The following is a description of a gene set: studied in species Mus musculus Mouse Gene Set: GOBP_RESPONSE_TO_INTERLEUKIN_17 Any process that results in a change in state or activity of a cell or an organism (in terms of movement, secretion, enzyme production, gene expression, etc.) as a result of an interleukin-17 stimulus., and this is the list of marker genes: Notch1, Il17ra, Il17f, Cntnap2 (contactin associated protein-like 2), Ccl1, Socs3, Traf5, Traf2, Traf6, Srsf1, Mir1896, Traf3ip2, Cxcl1, Il17a, Usp25, Trim32, Dcp1b, Il1b, Il6, Fmr1, Shank3, Nfkbiz, Nfkb1, Ikbke, Cxcl10, Mir409, Stat3